Given this list of marker genes Slc25a17, Acox1, Etfa, Cpt2, Acad11 (NCBI Gene Id 235565), Hsd17b4, Mlycd (NCBI Gene Id 56690), Hadha, Adipoq, Cyp4f18, Irs2, Lipe, Acad10, Nudt8, Lpin1, Aig1, Pck2, Dbi, Akt1, Acaa2, Pex13, Cpt1a, Acads, Crat, Cyp4f15, Nudt19, Decr2, Hadhb, Pex2, Cyp4f14, Auh, Acsbg2, Lpin2, Cyp4f40, Echs1, Acadvl, Acot7, Etfb, Hacl1, Bdh2, Irs1, Ehhadh, Ilvbl, Scp2, Abhd1, Ppard, Abcd4, Acsl5, Eci2, Decr1, Acaa1b, Lpin3, Pck1, Acad12, Ivd, Echdc2, Abcd3, Etfdh, Acox2, Pex7, Hadh, Abhd2, Adtrp, Fabp1, Etfbkmt, Twist1 (twist basic helix-loop-helix transcription factor 1), Acadl, Cyp4f13, Nudt7, Echdc1, Faah, Phyh, Slc27a2, Akt2, Abhd3, Lep, Sesn2, Abcd1, Lonp2, Acoxl, Eci3, Pex5, Acadm, Ech1, Acacb, Slc27a4, Acox3, Gcdh, Acat1, Abcb11, Tysnd1, Ces1d, Eci1, Hao1, Abcd2, Acot8, Hsd17b10, Plin5, Mtln, Mtor, Cpt1b, Ces1f, Acaa1a, Obp2a, Cnr1, Mfsd2a, Crot, Aldh1l2, here is a description of the gene set: Mouse Gene Set: GOBP_FATTY_ACID_CATABOLIC_PROCESS The chemical reactions and pathways resulting in the breakdown of a fatty acid, any of the aliphatic monocarboxylic acids that can be liberated by hydrolysis from naturally occurring fats and oils. Fatty acids are predominantly straight-chain acids of 4 to 24 carbon atoms, which may be saturated or unsaturated; branched fatty acids and hydroxy fatty acids also occur, and very long chain acids of over 30 carbons are found in waxes. species: Mus musculus